Given this list of marker genes Hip1r, Lancl2, Amer2, Akt1, Anxa8, Twf1, Snx11, Snx21, Dab2ip, Hcn1, Wipi2, Dennd1b, Zfyve19, Wipi1, Krit1, Actn2, Mtss2, Clvs2, Chmp3, Syt7, Kcnj1 (potassium inwardly-rectifying channel, subfamily J, member 1), Dnm2, Iqgap2, Cert1, Capg, Arhgap9, Rs1, Dab2, Kcnj3, Adap2, Snx24, Plek2, Fundc2b, Veph1, Tpcn2 (NCBI Gene Id 233979), Acap2, Rlbp1, Inppl1, Pfn1, Snx3, Asap1, Arfip1, Gramd2a, Vill, Laptm4b, Scin, Fundc2, Pla2g4a, Cadps, Adap1, Snx10, Gab2, Kcnh1, Plekha4, Pirt, Syt5, Alox15, Rnf34, Defb6, Ttpa, Rufy4, Jph2, Kcnj2, Twf2, Rcsd1, Snx14, Osbpl5, Zfyve1, Snap91, Arap2, Syt1, Sh3pxd2b, Tom1, Gsdmd, Cfl1, Amer3, Plekhn1, Sap30l, Kif16b, Pla2g4e, Mbl2 (NCBI Gene Id 17195), Bbs5, Fgd2, Sytl2, Myo1b, Snx13, Zfyve16, Gbf1, Amer1, Washc2, Vps13b, Btk, Mark1, Nrgn, Osbpl2 (NCBI Gene Id 228983), Avil, Gsdmc3, Ttpal, Dennd1a, Dapp1, Zfyve28, Phlda3, Rab35, Zfyve26, Snx18, Osbp, Exoc1, Snx22, Syt9, Fzd7, Tulp1, Mapkap1, Gsdmc, Defb7, Hip1, Ogt, Dnm1, Gsn, Plekhf1, Snx4, Fchsd2, Defb8, Tpcn1 (NCBI Gene Id 338536), Golph3, Plekha8, Atp13a2, Iqgap1, Plekha3, Syt3, Commd1, Kcnq1, Snx5, Pfn2, Plcb1, Arap3, Osbpl8, Defb4, Clvs1, Syt10, Rag2, Ankfy1, Defb5 (NCBI Gene Id 81007), Rbsn, Frmpd4, Plcz1, Vps36, Plcd1, Gsdmc2 (NCBI Gene Id 331063), Plekha5, Nlrp3, Vil1, Sh3pxd2a, Pard3, Fermt2, Arfip2, Rubcn, Snx27, Npm1, Tirap, Tecpr1, Snx20, Gap43, Obscn, Golph3l, Sdcbp, Racgap1, Dennd1c, Atg2a, Snx12, Apba1, Ldlrap1, Myo10, Gsdma2, Gsdma, Exoc7, Gsdme, Svil, Gsdma3 (NCBI Gene Id 450219), Rubcnl, Sdcbp2, Atg2b, Cyth3, Fcho2, Rph3a, Wdr45b, Irgm1, Gsdmc4, Myo1g, Flii, Ncf4, Cgas, Phlda2, Wdr45, Arhgap32 (Rho GTPase activating protein 32), Picalm, Phlda1, Anxa2, Sestd1, Mbl1, Arap1, Plekhb2, Defb3, here is a description of the gene set: studied in species Mus musculus Binding to phosphatidylinositol phosphate. Mouse Gene Set: GOMF_PHOSPHATIDYLINOSITOL_PHOSPHATE_BINDING